The following is a description of a gene set: species: Mus musculus Mouse Gene Set: GOBP_MEIOTIC_CHROMOSOME_SEPARATION The process in which chromosomes are physically detached from each other during meiosis., and this is the list of marker genes: Chfr, Sycp3, Ncaph, Top2a, Espl1, Ttk, Ncapd3, Zwint, Mapk15, Knl1, Mos (NCBI Gene Id 17451), Ncaph2, M1ap